The following is a description of a gene set: Language impairment Language impairment is a deficit in comprehension or production of language that includes reduced vocabulary, limited sentence structure, or impairments in written or spoken communication. Language abilities are substantially and quantifiably below age expectations. species: Homo sapiens Human Gene Set: HP_LANGUAGE_IMPAIRMENT, and this is the list of marker genes: CWF19L1, WARS2, MATR3, TCOF1, NSRP1, LMNB1, DLG1, NUP54, MSL3, SPTAN1, KCNN2, VLDLR, HNRNPH2, UNC13A, NFIX, CREBBP, PGK1, MAN2C1, RNU7-1, GLB1 (NCBI Gene Id 2720), MEG3, ATAD3A, POT1, NME5, LIG4, COPB1, SPOP, TECR, AP1S2, MESD, ODAD2, KIDINS220, DEAF1, ADD3, FOXRED1, CRAT, ZBTB7A, KCNH5, MFF, KDM3B, CUL3, SPR, CIT (citron rho-interacting serine/threonine kinase), SRPX2, NECTIN1, CCDC39, EP300, SLC9A7, AIFM1, BBS10, NPAP1, NUP107, SLC6A3, MTPAP, TMEM231, AMER1, OSGEP, TMEM63C, CWC27 (NCBI Gene Id 10283), GNB2, FREM1, SPTBN1, PLK4, IRF2BPL, CSNK2A1, MKKS (MKKS centrosomal shuttling protein), PWAR1 (Prader Willi/Angelman region RNA 1), GLI2, SMC1A, ANXA11, MAPRE2, HUWE1, PGAP2, KPTN, EHMT1, C19orf12, ANKRD11, UBE2A, CDON, SLC2A3, EIF4A3, CNNM2, LHX1, ERMARD (ER membrane associated RNA degradation), ZSWIM6, HNF1B, SUOX, UQCRQ, TPRN, CUX1, TRPV6, GMPPB, FOXJ1, CNTNAP2, THOC6, GNB1, MCTP2, GRIA1, FBXW7, PURA, CRELD1, TUBB4A, DISP1, HIKESHI, FBLN1, KDM6B, FTH1, AMPD2, NDUFA8, ALDH4A1, NUP62, HERC1, SPTBN2, MEIS2, BRWD3, NRAS, EIF3F, PARS2, SMARCE1, EXTL3, PDGFRA, PIGG, MAGEL2, MBOAT7, KAT6B, GRHL3, LRP5, SPART, TPK1, HK1, RBMX (RNA binding motif protein X-linked), RRM2B, TWIST1, ATP6V1E1, BRPF1, CACNA2D1, TOMM40, GNPTAB, ERI1, BRCA1, PMPCB (peptidase, mitochondrial processing subunit beta, NCBI Gene Id 9512), SATB2, EIF2AK1, GRIN2D, SGCB, SDHB, PDPN, ABCA7, HOXA2, POU3F3, NUDT2, PLCH1, ODAD4, DCC, YME1L1, ATXN2, CLTC, KDM6A, RARS2, GFM2, TRAPPC10, MRE11, MAST1, SCNM1, DCPS (decapping enzyme, scavenger), SCO2, EBP, WDR4, SLC4A10, GNAI1, CFAP410, MTHFS, CRKL, SPEN, PGAP1, BRF1, SLC2A1, FGFR1, CCDC28B, UBA5, ACSF3, MT-ATP6, DHX30, GRIN2B, ALG13, POLR1A, POLR1D, ARID1A, EMC1, BBS9, TIAM1, UGT1A1 (NCBI Gene Id 54658), TCF4, LRRC56, HNRNPA2B1, IVD, DYNC2I2, CCNK, POLD1, TMEM222, KCNAB2, MPDU1, ATG7 (NCBI Gene Id 105376952), THUMPD1, MAPT, WBP4, TUBB, KYNU, KCNA2, CASZ1, CLDN11, KLHL15, AP2M1, PRUNE1, FRA10AC1, ACOX2, GRIA3, ARHGAP29, CAMK2A, SLC35B2, NALCN, SPAG1, NEK1, PRKAR1B, OTUD6B, PUF60, CFAP418 (NCBI Gene Id 157657), FRMD4A, TAF15, FBXO11, BBS7, DLL1 (NCBI Gene Id 28514), TBC1D24, PRR12, SOX5, NTRK2, SLC25A42, SHH, STX1B, TRRAP, CHD2, SERAC1, KIF4A, BMPR1B, KIF15 (kinesin family member 15), PRPS1 (NCBI Gene Id 8254), SYT1, TAF4, GRIA2, SLC25A12 (NCBI Gene Id 8604), SETBP1, GEMIN5, NCDN, TBL1XR1, FTCD, DCX, TINF2, TMEM163, TRIO, ALG14, CACNA1E, HEPACAM, MCIDAS, ATP6V0A1, MACF1, RUBCN, POLR3B, SNORD116-1, KMT2E, SPP1, KMT2D, KDM1A, PTS, DEGS1, SF3B4, DYNC1H1, ASH1L, ADCY5, VPS11, WDR37, SLC16A2, TRAPPC2L, STAG2, GET4 (guided entry of tail-anchored proteins factor 4), SLC30A9, ZBTB11, RTTN, NDUFA1, FILIP1, LTBP4, PRPH, ZFX, ACADS, CACNA1B (NCBI Gene Id 774), ACOX1, ERCC2, AP1G1, TOR1A, CENPJ, TRIM32, POMT2, TNIK, PSMG2, KDM5B, EIF2S3, NCAPD2, DYRK1A, WDPCP, SZT2, REPS1, TGIF1, SIN3A, TSPAN7, ALG11, MKS1, POMT1, GPC4, TBK1, ANKRD17, PLPBP, TCEAL1, SLC1A2, MSX1, KCNMA1, LUZP1, TPP1, DNAAF6, ZBTB18, PTEN, TRIT1, TWIST2, BIN1, CACNA2D2, ARID1B, UFM1, NFIB, LINGO1, NIPA1, WDR26, NFE2L2 (NFE2 like bZIP transcription factor 2), KDM4B, GABBR1, L1CAM, HS6ST2, NLGN4X, NXN, PI4KA (phosphatidylinositol 4-kinase alpha), LZTFL1, ATP6V0A2, CHD8, TRIP4, NEDD4L, TANGO2, ATP6AP2, TCTN2, DPYS, PUS7, PCYT2, BBS12, COG8, BCR, CAMK2B, GORAB, DNAAF5, FLII, PHKA2, SLC6A8, CHMP1A, KNL1, TSPOAP1, MBD5, CCDC174, RYR3, CLIC2, GABRD, PLCB4, RSPH9, KDM5A, KARS1, KIAA0586, GMPPA, CACNA1G, EIF4A2, SATB1, PIGP, TNRC6B, GJA5, AP4B1, MED23, ATN1, PPIL1, DNAAF1, ZNF462, PAFAH1B1, FOXH1 (forkhead box H1), PACS2, SVBP, VPS41, IREB2, EED, FMN2, CHD5, DHDDS, PSEN2, IQSEC2, VPS37A, MORC2, NSDHL, ZMIZ1, APC2, DDX6, AP3B2, DNAI2, PLP1, PTCH1, SYNGAP1, TRAF7 (TNF receptor associated factor 7), FGF8, CLN8, TTI2 (NCBI Gene Id 80185), AMFR, GOLGA2, JAG2 (jagged canonical Notch ligand 2), TMTC3, RAI1, NLGN3, RSRC1, HNRNPH1, FBXW11, ACSL4, WDR81, QRICH1, NT5C2, DPP9, GNB5, DOCK3, TP53RK, TMLHE, ZEB2, ZBTB20, PLA2G6, TRAPPC14, SLC6A17, TLK2, CIC, RAB18, KCNH1, ALDOA, TCF20, COA8, CDH1, CDKN1C, ODAD1, SRCAP, KMT2A, BRD4, CERS1, FANCF, TM4SF20, ADARB1, DOHH, RAB11B, DPAGT1, HTT, SRRM2, RSPH1, CDK19, SDHD, GNAO1, DRC1, ADSL, SCAPER, KCNA4, DCLRE1B, DYNC1I2, PLAA, SPRED1, OXR1 (NCBI Gene Id 55074), GJB1, FOXP2, TMEM94, FDXR, GMNN, TSEN15, BCORL1, SDCCAG8, ARF1, RIC1 (NCBI Gene Id 57589), PPP2R1A, EXOSC2, NIPA2, WWOX, SLC39A14, MCOLN1 (mucolipin TRP cation channel 1), BCAS3, FRMPD4, UFC1, TAF2, CACNA1I, FIBP, ZNF292, CEP290, AHDC1, DOLK, TTC5, PIGV, PEX1, PCGF2, MYO9A, DAO, GPT2, CHKA (choline kinase alpha), PHF21A, CEP63, H3-3A, COG3, PDE4D, NGLY1, SMAD4 (NCBI Gene Id 4089), DNAI1, TRAPPC6B, CACNA1C (calcium voltage-gated channel subunit alpha1 C), PMPCA, GLT8D1 (NCBI Gene Id 91870), TEFM, PRKRA, SLC6A19, HS2ST1, GNAQ, WLS, KAT8 (lysine acetyltransferase 8), NR2F1, POR, GLE1, CUBN, KMT2C, MADD, CEP19, CARS1, EEF1A2, TMEM106B, TKFC, TOGARAM1, SIK3, COG4, DCTN1, ZNF711, ASXL3, MRPS14, GABRG2, ADAT3, DLK1, ATXN3, RAB3GAP2, GRB10, ARMC9, TANC2, SNRPN, EXOSC5, SDHAF1, SLC12A2, MFSD2A, WDR73, CNOT2, PON2, MED27, TUBA8, MCM3AP, GLS, FKRP, ITPR1, BMP4, RSPRY1, ZIC2, UBAP2L, GJA8, COG1, SETD1B, SLC6A1, DALRD3, EBF3, LAGE3, SHANK3, PON3 (paraoxonase 3), AMMECR1, PI4K2A, RPS6KA3, KCNA1, BBS4, DPM2, FKTN, THRB, PPP3CA, RSPH4A, SFXN4, COG5, SPTSSA, BBIP1, GABBR2, KPNA3, SLC32A1, POGZ, DNAH1, ADAR, RNASET2, AUH, PFN1, RNU4-2, HNRNPK, ATP6V1A, CCNO, ASL, CDK13, TELO2, CLCN4, FBXL3, NSUN2, SIK1, HDAC4, ESAM, IFT74, DMD, OTUD7A, ATP5F1A, PPARGC1A, ACTL6B, KCNJ10, APP, ZMYND11, ASPA, SDHA, UGP2, DAG1, CC2D1A, PPP1CB, RRP7A, USP27X, DENND5A, SNORD115-1, TRAPPC9, CCND2, NACC1, KCNK4, RNF125, RPL10, NECAP1, NF1 (NCBI Gene Id 646021), GABRB2, POLR1B, DNAH11, HERC2, OTOG, TNNT1, YIF1B, UBE3A, CRADD, EXOSC3, PRDM16, CYFIP2, GCDH, NONO, MED12, IQSEC1, DOCK7, SMARCB1, CSPP1, GALNT2, DPF2 (double PHD fingers 2), MRPS34, NBN, ZMYM3, NUS1, SETD1A, SLC44A1, NR4A2, DNM1L, DPYSL5, SPTBN4, PIGN, ROGDI, CNOT1, BLTP1, RORB, HACE1, TUBB2A, B3GALT6, OPHN1, MN1, TRIM8, EXT2, RAB5IF (RAB5 interacting factor), LMBRD2, AGO2, DLX4, OPTN, SCLT1, PIGF, STXBP1, CLPB, LRPPRC, EZH2, SOX11, SELENOI, CCDC47, ARHGEF2, WDR62, CAPRIN1, MAPK1, UBTF, ARPC4, AASS, GLI3, MED25, TBCK, SLC17A5, SIAH1, PSEN1, NBEA, EIF2AK2, CACNA1A, POLR3K, INTS8, BCL11B, IFIH1, GRID2, CTBP1, NME8, TMCO1, GAMT (NCBI Gene Id 2593), CLP1, GRIA4, NEK10, CCNF, ALMS1, PSMC1, HMGA2, AARS1, NAXD, SAT1, UBE3B, UBE4A, HOXB1, DOCK6, VCP, HCN4, SOD1, CDK10, SUPT16H, SLC12A6, ODAD3 (NCBI Gene Id 115948), TFE3, RMND1, SQSTM1, TREM2, OCA2, TBC1D23, DNAJC12, ANK3, ZNF142, SNX14 (NCBI Gene Id 57231), HNMT, KCNQ5, SLITRK2, BSCL2, DYM, TUBB3, BPTF, EFTUD2, SOX4, OGDH, TP63, SLC35C1, CAMTA1, ACBD5, UBA2, TKT, ARL13B, SCN4A, SCN8A, NPHP1, POU4F1, UBB, DHTKD1, SLC35A2, PUS3, SYNJ1, ARID2, MMP23B, MAN2B1, CAMK2G, SMG9 (SMG9 nonsense mediated mRNA decay factor), ALDH18A1, SNF8, CFAP298, UNC80, PHKG2, LINS1 (NCBI Gene Id 55180), TBCE, WDR45, SCAF4, DNAJB13, DNAAF11, AGA, RHOBTB2, ACBD6 (acyl-CoA binding domain containing 6), TTC8, KCNT1, ASCC3, METTL5, LNPK, FARS2, KANSL1, DNMT3A, PSMD12, KDM5C, ADNP, CPLX1, VARS1, CARS2, CRIPTO, TRAK1, SORL1, XRCC4, WASF1, NAA15, KCNC2, KMT5B, AFG2A, LARGE1, ISCA2, GLYCTK, FTSJ1, DNM1, YY1, SPEG, PLAG1, GATAD2B, AIMP2, SMO, SCN1A, TH, ASPM, BAP1, PRMT7, MKRN3, NSD1, CASK, GNAS, RORA, ALG2, PHKB, YARS1, TRMT1, BBS1, SEC23A, KIAA0753, IARS1, ERLIN2, RALGAPA1, KMT2B, VAPB (NCBI Gene Id 9217), RFC1, DPH5, SKI, OFD1, MICU1 (mitochondrial calcium uptake 1), ELP2, NOVA2, KCNB1, CFAP221, NDN, CUL4B, PYCR2, CHCHD10, TNPO2, NDST1, STK36, RPGR, GSX2, H4C11, AGTPBP1, PRKD1, NODAL, AFF2, PRKCZ, GNAI3, STIL, SPARC, MAB21L1, COL3A1, COBLL1, CTCF, HID1, DPYD, FBXO28, DNAAF2, BCKDK, SPEF2, IGF1R, GALE, PPFIBP1, SMARCD1, POLR1C, ST3GAL5, NEXMIF, TIMM50, NEFH, HYDIN, GABRA2, RSPH3, MDH2, PPP2R5D, PBX1, CASP2, RTL1, CELF2, CTNNA2, TARDBP, PPM1D, JAG1, INTS1, CHAMP1, CEP295, FUS, INPP5E, CLCN3, FOCAD, INTU, USP7, FRRS1L, CHMP2B, DNAH9, GRM1, LMNB2, FOXG1, ARX, LSS, SOBP, GRIN2A, SRPK3, RLIM, NARS1, DNAAF3, VAC14, ARFGEF1, BBS2, SLC13A5, TTC12, ARL6, ZC4H2, H4C5, NSUN6, GLRA2, MAP1B, SET, NOTCH3 (notch receptor 3), ADGRG1, CSTF2, CCDC88A, YWHAG, DLG3, EMC10, SLC38A3, UBQLN2, MYT1L, SIM1, SH2B1, ODC1, PGM2L1, TBX1, PSMB1, PIGO, GATM, MINPP1, FGF13, KIF1A, SHROOM4, TSHR, GRIN1, PGAP3, NCAPG2, LEMD3, TBC1D7, GEMIN4, SHMT2, LMX1B, BBS5, GOT2, ATM, NDUFA4, HCN1, ORC6 (NCBI Gene Id 23594), ADGRL1, SLC33A1, PRRT2, CHKB, IGF2, RIMS2, FIG4, PIK3R1, PIGW, LRRC32, ANG, HSPG2, SLC1A4, RERE, MRPL12, PON1, TAF8, PNPT1, SIX3, AMN, ERBB4, ALG12, SMARCC2, PPP2CA, VPS33A, PIGA, ZMYM2, MRAS, PCDH19, TRPM3, TTI1, IFT172, INTS11, ATP9A, GRIK2, MSTO1, SMARCA2, DMPK, UBE4B, XYLT1, ABCB7, TOE1, PIGM, FZR1, FOXP1, TRIP12, ASXL2, IFT27 (NCBI Gene Id 11020), RAP1GDS1, GJA1, GRN, PWRN1, ACAD8, ZMYND10 (zinc finger MYND-type containing 10), ATP6V0C (ATPase H+ transporting V0 subunit c), STT3A, TAF1, ATP5F1D, FAR1, TAOK1, KAT6A, TMEM147, POMGNT2, FERRY3, WAC, PAK3 (p21 (RAC1) activated kinase 3), STAT4, PYCR1, VPS13B (vacuolar protein sorting 13 homolog B), ZNF407, SMAD6, ATP1A3, GALT, ASXL1, POLRMT, PMM2, MEF2C, CNKSR2, CBL, GABRA5, HSD17B10, SCN3A, BRAT1, RALA, FMR1 (fragile X messenger ribonucleoprotein 1), SLC1A3, DNAH5, BTK, KCTD7, CDC42, MECP2, MED13L, AGO1, TBC1D20 (NCBI Gene Id 170488), HIVEP2, LIPT2, IRF6, MED12L, UFSP2, FLNA, ERF, SEMA6B, PDE2A, STAG1, PACS1, NEMF, AIMP1, LAS1L, HNRNPU, TENM3, DARS2, VPS4A, HECW2, ARHGEF38, ABHD16A, RUSC2, GAS2L2, USP9X (NCBI Gene Id 8239), TRAPPC11, TBCD, TBR1, WASHC4, NTNG2, CRBN, GPC3, CHD3, ALDH7A1, HNRNPA1, DNAAF4, CFAP300, ATP10A, CFAP74, MARS1, THOC2, SETD2, LAMA1, LMAN2L, DHPS (NCBI Gene Id 1725), WDR45B, SMS, RAP1B, NIPBL, COG6, TBX4, CDKL5, SMARCA4, PRODH, TUBG1, RNF113A, EN1, TENT5A, TTN, KIF5C, ATP1A2, TET3, HNRNPC, MED13, ADK, SLC25A46, WIPI2, GAS2, SETD5, SLC25A36, PIGS, FGF12, AUTS2, EARS2, GPAA1, COX20, C2CD3, WARS1, RYR1, PRNP, GNE, TREX1, STRADA, FLCN, RAC1, PAK1, MTFMT (NCBI Gene Id 123263), RFX7, ACADM, SHQ1 (NCBI Gene Id 55164), IRAK1, GNS, PHF8, MFSD8, DNAL1 (NCBI Gene Id 83544), CCDC40, SLC9A6, TNR, GAS1, ALDH5A1